The following is a description of a gene set: studied in species Mus musculus Mouse Gene Set: GOBP_MESONEPHRIC_DUCT_DEVELOPMENT The process whose specific outcome is the progression of a mesonephric duct over time, from its initial formation to a mature structure. A mesonephric duct is a tube drains the mesonephros., and this is the list of marker genes: Lhx1, Mir217, Hnf1b, Osr1, Pkd1, Mir216a, Pkd2, Greb1l, Wnt11, Wnt9b, Pax2, Mir216b, Gpc3 (NCBI Gene Id 14734)